The following is a description of a gene set: Human Gene Set: MIR4534 from publication Chen Y, Wang X (PMID 31504780) Genes predicted to be targets of miRBase v22 microRNA hsa-miR-4534 in miRDB v6.0 with MirTarget v4 prediction scores > 80 (high confidence targets). studied in species Homo sapiens, and this is the list of marker genes: INTS6, TBC1D25, MSL3, MTMR14, SLC31A1, SLC35E1, TAC3, SOX6, CMTM7, FCMR, AKAP13, ZMYND11, MTCL1 (NCBI Gene Id 23255), PAX7, ALG12, MOSPD1, ZNF264, AP4E1, FIGNL2, PXMP4, NECAP1, ERICH3, MR1, MILR1, ST6GAL1, MTG2, ASAP2, ERCC1, TIGIT, REL, DCX, HGSNAT, CXorf58, KDM2A, CLCA2, OLA1, FUNDC2 (FUN14 domain containing 2), LRRC8A, TAOK3, FAM161A, FAM217A, JMJD6, SMYD1, NCAN (neurocan), GNG13, SCN2B, CHRNB2, NR6A1, IL6ST, SLC25A36, NETO1, PURG, ST8SIA3, CHST3, ERC1, ATG2B, ALDH9A1, KCNS1, MS4A1, ATP12A, C2CD5, SLC35F2, NOVA2, NOP9, EIF4E, DDTL, FAM169BP, FOXQ1, RDH10, GNPDA1, RGL1, SRPX, VWC2, SCN3B, CER1, BET1L, ZMIZ1, LPCAT2, NCAPH, MYO18A, CNOT9, KLHL42, ALDH16A1, GYPC, FAM120C, GSG1L, IGLON5, MARK1, PGR, STON2, FAM222B, NT5E, GLT8D1, TRPA1, ZNF142, ARHGAP12, RAB5IF, SLC44A5, XIRP1, LRRTM2, PHTF2, SPN, SLC35A3, VPS53, ESRRG, LHFPL3, GPR84, POGK, C8orf44, OLR1, NAB1, FXR2, CACNG3, ST8SIA2, DTNA, CCND2, PPM1K, HOMER1, UGDH (NCBI Gene Id 7358), RNF10, NUBP1, WWC1, HECTD3, GFRA1, KCNQ4, TSPAN14, PLCXD2, PPP3R1, ADAM12, ARHGAP28, SPAG17, HECW2 (HECT, C2 and WW domain containing E3 ubiquitin protein ligase 2), IGF2, ZNF213, ZKSCAN1, ATF7, TGIF2-RAB5IF, ZNF813, CCDC40, CCDC121, JARID2, TENT2, SH3BGRL3, TMPPE, TMEM168, TNRC18, NUMBL, FOSL1, EFHC1, HMGCLL1, ADCY1, MOG, MIEF1, GNG2, FNDC10, PPAT, LIMCH1, OPRM1, DAAM2, SRGAP2, TOM1L2